The following is a description of a gene set: Malignant neoplasm of the central nervous system species: Homo sapiens Human Gene Set: HP_MALIGNANT_NEOPLASM_OF_THE_CENTRAL_NERVOUS_SYSTEM A tumor that originates in the pineal gland, has moderate cellularity and tends to form rosette patterns., and this is the list of marker genes: KEAP1, UBE4B, LIN28B, TSC1, EPCAM, PIK3CA, APC, LUZP1, SEMA4A, TP53, SMO, KRAS, MYO1H, BRD4, GPR161, HACE1, CTNNB1, GABRD, NF1, ZFTA, CASZ1, SMARCB1, TUBB, CDKN2B, PALB2, PTCH1, ASCL1, MUTYH, KIF1B, MMP23B, FGFR1, HSPG2, NF2, NBN, EDN3, LBX1, MSH3, PTPN11, SKI, IFNG, IDH1, IDH2, MLH1, MAPRE2, BDNF, RUNX1, PDPN, MSH2, ASXL1, PRKCZ, CDKN2A, PMS1, KCNAB2, RAF1, SUFU, LMO1, MSH6, SDHB, PDCD10, TSC2, RERE, POLE, YY1, CHEK2, CDKN2C, ATM, CDKN1B, CDKN1A, APC2, ERBB2, GDNF, MDM2, CCM2, ELP1, SPRED1, KRIT1, BRAF, POLD1, NSD1, RPS20, PMS2, PTCH2, BMPR1A, TGFBR2, GPC3, PHOX2B, PRDM16, PTEN, MEN1, GPC4, MYCN, BRCA2, RET, SETBP1 (NCBI Gene Id 284262), DICER1, SPEN, ALK, NUTM1